The following is a description of a gene set: species: Homo sapiens Binds to and modulates the activity of an enzyme that catalyzes a ring closure reaction. Human Gene Set: GOMF_CYCLASE_REGULATOR_ACTIVITY, and this is the list of marker genes: NHERF4, RAF1, GNAI1, GUCA1A, RCVRN (NCBI Gene Id 5957), ADGRV1, NCS1, GUCA2A, RGS2, GNAS, CALM2, GUCA1C, GNAO1, GUCA2B, GUCA1ANB-GUCA1A, CALM1, CALM3, GRM7, GNAZ, GUCA1B, GNAL